Given this list of marker genes Kcnj11, Gcg, Ffar1, Kcng2, Gnai1, Plcb3, Gng3, Cacna1a, Gnb3, Gnb5, Slc2a1, Gngt1, Acsl4, Gngt2, Gnb2, Adcy5, Prkacb, Gng4, Adra2c (NCBI Gene Id 11553), Gng7, Gna14, Gng11, Cacnb3, Adra2a (NCBI Gene Id 11551), Cacna2d2, Gng8, Gng10, Kcnb1, Gng5, Prkaca, Prkca, Cd36, Glp1r, Marcks, here is a description of the gene set: part of: Integration of energy metabolism electronically inferred by orthology from the curated human pathway species: Mus musculus This event has been computationally inferred from an event that has been demonstrated in another species.<p>The inference is based on the homology mapping from PANTHER. Briefly, reactions for which all involved PhysicalEntities (in input, output and catalyst) have a mapped orthologue/paralogue (for complexes at least 75% of components must have a mapping) are inferred to the other species. Reactome Pathway: Regulation of insulin secretion